The following is a description of a gene set: Chemically induced mouse skin carcinogenesis represents the most extensively utilized animal model to unravel the multistage nature of tumour development and to design novel therapeutic concepts of human epithelial neoplasia. We combined this tumour model with comprehensive gene expression analysis and could identify a large set of novel tumour-associated genes that have not been associated with epithelial skin cancer development yet. Expression data of selected genes were confirmed by semiquantitative and quantitative RT-PCR as well as in situ hybridization and immunofluorescence analysis on mouse tumour sections. Enhanced expression of genes identified in our screen was also demonstrated in mouse keratinocyte cell lines that form tumours in vivo. Self-organizing map clustering was performed to identify different kinetics of gene expression and coregulation during skin cancer progression. Detailed analysis of differential expressed genes according to their functional annotation confirmed the involvement of several biological processes, such as regulation of cell cycle, apoptosis, extracellular proteolysis and cell adhesion, during skin malignancy. Finally, we detected high transcript levels of ANXA1, LCN2 and S100A8 as well as reduced levels for NDR2 protein in human skin tumour specimens demonstrating that tumour-associated genes identified in the chemically induced tumour model might be of great relevance for the understanding of human epithelial malignancies as well. Genes down-regulated in malignant skin tumors (squamous cell carcinoma, SCC) formed by treatment with DMBA and TPA in the two stage skin carcinogenesis model. Mouse Gene Set: HUMMERICH_MALIGNANT_SKIN_TUMOR_DN from publication Hummerich L, Müller R, Hess J, Kokocinski F, Hahn M, Fürstenberger G, Mauch C, Lichter P, Angel P (PMID 16247483) species: Mus musculus, and this is the list of marker genes: Mylpf, Ccl27a, Alb, Cox6a2, Snx7, Tnni2, Pcdh12, Car3, Tnnt3, Retnla, Tnnc2, Ifi27l2a, Scand1, Cfd, Myh2, Ckm, Atp2a1, Plxnb2, Aff1, Myh8